Given this list of marker genes Matk, Erbb2, Ptpn18, Egfr, Uba52rt, Nrg1, Erbb3, Ereg, Btc, Cdc37, Akt2, Ptpn12, Uba52, Erbin, Ubb, Akt3, Rps27a, Egf, Usp8, Hbegf, Hsp90aa1, Rnf41, Erbb4, Akt1, Ubc, Nrg3, Stub1 (STIP1 homology and U-Box containing protein 1), here is a description of the gene set: Downregulation of ERBB2 signaling species: Mus musculus Mouse Gene Set: REACTOME_DOWNREGULATION_OF_ERBB2_SIGNALING